The following is a description of a gene set: The aim of this dataset was to study in detail the transcription kinetics initiated by cytokine IL-4 in early differentiation of Th2 cells. Human Gene Set: GSE17974_IL4_AND_ANTI_IL12_VS_UNTREATED_24H_ACT_CD4_TCELL_UP species: Homo sapiens Genes up-regulated in comparison of CD4 T cells treated with IL4 and anti-IL12 at 24 h versus the untreated cells at 24 h. from publication Elo LL, Järvenpää H, Tuomela S, Raghav S, Ahlfors H, Laurila K, Gupta B, Lund RJ, Tahvanainen J, Hawkins RD, Oresic M, Lähdesmäki H, Rasool O, Rao KV, Aittokallio T, Lahesmaa R (PMID 20620947), and this is the list of marker genes: MEST, ABHD6, BCL2L11 (NCBI Gene Id 150819), PPP1R14A, CCDC17, PPARG, OBP2A, OR5E1P, SLC40A1, TPRG1 (tumor protein p63 regulated 1), CCL22, ASIC3, CLCN6, CLECL1P, CCDC148-AS1, GOLGA8IP, STPG3, DLC1, TMEM277P, CEP57L1, GSTA4, CACNG8, SPATA3-AS1, VCF2, PKIA, GSTT4, XPO4, ADORA1, EPB41L5 (NCBI Gene Id 80242), DSCR10, CHPF2, ATPAF2, SPMIP9, SLC6A18, GAB2, CTNS, ENSG00000224715, ADGRV1 (adhesion G protein-coupled receptor V1), LINC01107, FGF10 (NCBI Gene Id 2255), TNFSF11, KRT1, NTRK1, NFASC, GPR20, GNAI1, DIO3OS, PTPRD, LRRTM1, CLEC11A, PRKCQ-AS1, ELAPOR2 (endosome-lysosome associated apoptosis and autophagy regulator family member 2), WDR86-AS1, GPR12, HAPLN4, CSMD1, BTBD16, GRIN2B, CSF1 (NCBI Gene Id 1435), RAB27B, C1orf162, SHOX2, PDE4A, LIPF, PCDH11X, CPT1A, SARDH, CD55, ZFYVE27, CD244, MAOB, CDHR5, RTN1, FOXQ1, SLC26A11, TESPA1, HSPB8, SPINT2, PRIMA1, ZFYVE28, BGLAP, REL-DT, PLA2G4A, STAT4, CCL17, HHIP-AS1, TMEM129, IFNA21, MPZL3, CSRP2, DUSP6, FNDC8, ALOX15, GPR183, DCHS1, ZNF365, RHOB, JRK, PGAM5, SLC9A9 (solute carrier family 9 member A9), FKBP2, ETV5 (ETS variant transcription factor 5), STEAP1B, C22orf42, NEU2, EFNA5, CCDC122 (coiled-coil domain containing 122), HRH4, ZNF704, LINGO1-AS1, MAOA, TMEM145, PNPLA5 (patatin like phospholipase domain containing 5), HERC2P1, GGT7, VXN, CFAP46, RAMP1, NEK6, ZNF443, ANK1, CD8A, MBOAT7, GNAO1-DT, PLA2G2A, USP35, IL17RB, RAPSN, KCTD7, SLC47A1, SGK1, LAIR1, GRAP2, ABCD3, PVALB, DNAH11, RRS1, VIPR1, TMEM200C, STRADB, MAGEA10, FREM1, THNSL2, TRGV5, GPC4, TAFA5, SNHG4, SYTL3, NRP2, REEP1, FNDC11, IL3, PCAT4, GATA3, SORBS2, LTC4S, LRRC32, ZNF839, CA4, APOBR, HCST, IGSF11, HOMER2 (homer scaffold protein 2), PINX1 (NCBI Gene Id 91819), IFNL1, DHRS3, TIMP4, ADHFE1, COX19, FATE1, NR1H3, KIR2DL3, TMEM254, PDE9A, NDUFV1-DT, NIPA1 (NIPA magnesium transporter 1), TRIM10, TIMP1, LINC01426, PDILT, COL10A1, TAS2R38, DNAH17-AS1 (DNAH17 antisense RNA 1), NRAV, PPY2P, MTNR1A, TNFRSF17